Given this list of marker genes TNKS2, PARP10, PARP4, PARP15, TIPARP, PARP16, TNKS, PARP11, PARP3, PARP14, PARP1, PARP2, here is a description of the gene set: Human Gene Set: GOMF_NADPLUS_PROTEIN_GLUTAMATE_ADP_RIBOSYLTRANSFERASE_ACTIVITY Catalysis of the reaction: L-glutamyl- + NAD+ = 5-O-(ADP-D-ribosyl)-L-glutamyl- + nicotinamide. studied in species Homo sapiens